The following is a description of a gene set: Mouse Gene Set: GOBP_SOMATIC_DIVERSIFICATION_OF_IMMUNOGLOBULINS_INVOLVED_IN_IMMUNE_RESPONSE The somatic process that results in the generation of sequence diversity of immunoglobulins after induction, and contributes to an immune response. species: Mus musculus, and this is the list of marker genes: Ercc1, Rnf168, Lig4, Cd40, Aicda, BC037156 (cDNA sequence BC037156), Mlh1, Kmt5c, Mad2l2, Clcf1, Cd28, Tfrc, Il27ra, Kmt5b, Ccr6, Rnf8, Aplf, Xrcc4, Il2, Mir181b-1, Hmces, Pms2, Hspd1, Foxp3, Nfkbiz, Icosl, Cd40lg, Il4, Swap70, Shld3, Ndfip1, Exosc6, Mir181b-2, Msh2, Pagr1a, Ifng, Parp3, Trp53bp1, Tbx21, Slc15a4, Nbn, Shld1, Sanbr, Tnfsf4, Supt6, Pcyt1a, Batf, Ung, Rif1, Nsd2, Tgfb1, Exosc3, Shld2, Ptprc, Stat6, Atad5, Tnfsf13, Msh6, Paxip1, Bcl6, Exo1